Given this list of marker genes Rps27a, Calr, Ubb, here is a description of the gene set: electronically inferred by orthology from the curated human pathway Reactome Pathway: Calnexin/calreticulin cycle This event has been computationally inferred from an event that has been demonstrated in another species.<p>The inference is based on the homology mapping from PANTHER. Briefly, reactions for which all involved PhysicalEntities (in input, output and catalyst) have a mapped orthologue/paralogue (for complexes at least 75% of components must have a mapping) are inferred to the other species. part of: N-glycan trimming in the ER and Calnexin/Calreticulin cycle studied in species Mus musculus